Given this list of marker genes Ube2v1, Tab3, Ikbkg, Birc3, Rps27a, Mapk12, Casp8, Ripk2, Casp1, Mapk11, Ubc, Tnfaip3, Traf6, Itch, Casp2, Nod1, Aamp, Cyld, Mapk14, Nod2, Mapk13, Ube2n, Uba52rt, Birc2, Tab1, Casp9, Tab2, Casp4, Map2k6, Uba52, Ubb, Map3k7, here is a description of the gene set: NOD1/2 Signaling Pathway Mouse Gene Set: REACTOME_NOD1_2_SIGNALING_PATHWAY species: Mus musculus